The following is a description of a gene set: studied in species Homo sapiens Enzyme inhibitors (esp serine proteases). Human Gene Set: MODULE_164, and this is the list of marker genes: CDKN1A, CST4, ITIH2, ANXA5, C5, SERPINF1 (NCBI Gene Id 5176), SPP2, PEBP1, C3, GCKR, PI3 (peptidase inhibitor 3), CDKN2A, PKIA, CSTA, SPINT2, ANXA4, CST7, SERPINB3, SERPINB8, TIMP3, SERPING1, ANXA2, CDKN1C (cyclin dependent kinase inhibitor 1C), TIMP2, CST6, SLPI, SERPINB5 (NCBI Gene Id 5268), SPINK1, DNAJC3, COL7A1, WFDC2, SFN, PSMF1, ANXA3, AMBP, ITIH3, APLP2, AGT, SERPINE1, PPP1R1A, CST1, SERPIND1, SERPINB6, CSTB, TFPI, A2M, GMFG, SERPINF2, BIRC5, TFPI2, SERPINC1, HRG, PTN, SCGB1A1, SERPINA6, C4B, COL6A3, ANXA1, SERPINB1, CST3, TIMP1